Given this list of marker genes Vmn1r217, Gm11371, Gm8245, Gm11307, Prl4a1, 4930557F10Rik, Gm11320, Snrp1c-ps2, Bphl, Ripor2, Serpinb9g, Gm5194, Gm47978, H4c9, Prss16, Gm40841, 4930511O05Rik, Vmn1r196, Gm30489, Vmn1r201, Gm22126, Gm11321, Serpinb1b, Zscan26, Rps17-ps1, Gm25186, Vmn1r190-ps, 4932702P03Rik, Fam217a, Gm11270, Cage1, Gm22452, H3c10, Bmp6, Gm11354, Prpf4b, Gm11394, Gm47754, Vmn1r-ps109, Vmn1r199, Serpinb9h, Prl3a1, Eci3, Gm46411, Gm36099, Prl8a1, Vmn1r-ps126, Gmnn, Vmn1r-ps133, E2f3, Gcm2, Vmn1r-ps101, Vmn1r-ps106, Vmn1r218, H2ac15, Or2b6, H2ac7, Prl7a2, H4c18, Tmem14c, Aldh5a1, Gm23774, Slc17a3, Gm8352, Vmn1r222, Gmds, Gm11355, Gm11366, H3c11, Prl3b1, Dcdc2a, Vmn1r194 (NCBI Gene Id 632575), D130043K22Rik, H2bc7, Vmn1r-ps125, Gm11381, H2bc23, BC005537, H2ac6, Nrn1, Gm35732, Lncbate6, Prl8a8, 2210022D18Rik, Mir1983, H2ac14-ps, Gm23351, Sycp2l, Gm29590, Gm40918, Prl3d2, Vmn1r-ps132, Hdgfl1, Gm8277, Nrsn1, H4c1, Vmn1r207, Serpinb9e, Gpx5, H1f3, Gm11360, Gm11298, H2bc12 (NCBI Gene Id 319184), Gm23206, H3c1, Ssr1, Gm40923, Gm11359, Gm5195, H2ac22, Rreb1, Vmn1r219, H2bc14, Dsp, Serpinb1-ps1, H4c2, 1110046J04Rik, Gm11282, Vmn1r221, 4933404K08Rik, Vmn1r-ps99, Prl2b1, Vmn1r188, Vmn1r210, Scgn, Tubb2b, Ripk1, Vmn1r205, H2bc6, Smim13, H2bc11, H1f5, Prl8a6 (prolactin family 8, subfamily a, member 6), 4930579J19Rik (RIKEN cDNA 4930579J19 gene), 5530402G07Rik, Btn2a2, Prl7b1, Gm40909 (predicted gene, 40909), Cmah, Gcnt2 (NCBI Gene Id 78281), Vmn1r223 (NCBI Gene Id 626774), Slc17a1, Agtr1a, H1f2, Gm10129, Gm19153, Zkscan8, A730081D07Rik, A230103O09Rik, Btn1a1, Acot13, Pxdc1, H4c3, Prl3d1, Gm3509, 5033403F01Rik, H1f1, Vmn1r202, H1f4, Gm22013, H2bc13, Prl2a1, Or2b7, Nqo2, Gm36500, Riok1, Prl8a9, Or2w6, Prl7a1, Gm35160, Prl3c1, Gm47038, Sox4, Gm11279, Vmn1r-ps113, Prl7c1, Gm40922, Serpinb9, Tfap2a, 1700018A04Rik, Vmn2r-ps94, Gm11285, Gm11353, Gm18881, Psmg4, Gm36758, Gm26688, H2ac1, Vmn1r-ps103, Tex56, 4930519D14Rik, Gm11378, Vmn1r204, H4c6, Foxq1, Gm23972, H4c11, Gm11372, H1f6, Mir5124a, Mir6368, Gm11350, Foxf2, Gm11278, Abt1, Gm23340, Or2w2, Vmn1r203, H2ac12, Vmn1r195, Zfp184, Gm5447, Prl3d3, Vmn1r-ps131, Gm11363, Vmn1r-ps112, Vmn1r-ps123, 1700019C18Rik, H2ac5-ps, Gm31834, H3c6, Lyrm4, H4c17 (H4 clustered histone 17), Gm11271, Prl, Gm11349, Vmn1r-ps94, Mboat1, Gm26395, Gm11362, Hfe, Tubb2a, 4930401O12Rik, Vmn1r-ps117, Mak, Serpinb1c, Serpinb9b, Gm31683, Gm11281, Gm11341, Gm11380, Vmn1r-ps120, Gm11342, A330102I10Rik, 9330162012Rik, Zkscan3, H3c3, Gm11322, Gm11377, 4930586N03Rik, H3c4, H2bc15, Wrnip1, Vmn1r211, Zkscan4, Gm22330, Gpx6, Gm11370, Serpinb9c, H2bc22, Vmn1r209, Vmn1r-ps108 (vomeronasal 1 receptor, pseudogene 108), H2bc4, Mrs2, H2ac24, Gm11338, H2ac23, 2610307P16Rik, AK157302, H2bc9, Mir1896, Foxc1, Gm11387, Serpinb6a, Vmn1r-ps111, Zfp389, Gm11398, Vmn1r193, H2ac13, 4930447K03Rik, H2ac4, Gm6129, A730091E23Rik, G630018N14Rik, Cdkal1, Serpinb6c, Ppp1r3g, Slc22a23, Prl8a2, Gm16984, H2ac11, Vmn1r-ps97, Vmn1r-ps107, Vmn1r-ps127 (vomeronasal 1 receptor, pseudogene 127), Gm9979, Gm4035, Vmn1r-ps102, Fam50b (family with sequence similarity 50, member B), Gm11292, Or2b2b, Vmn1r216 (vomeronasal 1 receptor 216), Gm36839, Vmn1r191, H4c4, H2bc3, Snrnp48, H4c12, Or2w4, Zscan12, Vmn1r200, Vmn1r214, Vmn1r197, C230035I16Rik (NCBI Gene Id 320842), Gm11295, Slc17a4, Gm6245, Slc35b3, Vmn1r-ps96, Gm46409, Or1f12, Pgbd1, H3c2, Gm22674, Slc17a2, Dusp22, 4933436N17Rik, Gm11351, 4930470G03Rik, Ly86, Irf4, Gm11379, H3c8, Gm18643, Vmn1r-ps92, Vmn1r208, Gm46392, Serpinb6b, H2bc8, Gm23779, Gm47990, H4c8, Vmn1r192, Prl2c1, Vmn1r-ps128, Gm11274, Uqcrfs1, Gm40828, Gpld1, AI463229 (expressed sequence AI463229), Gm11337, Tdp2, Serpinb1a, Gm11343, H2ac10, Txndc5, Gm11392 (NCBI Gene Id 624716), Bloc1s5, Gm11318, Cox5b-ps, Vmn1r212, Pak1ip1, Mylk4, Vmn1r220, Gm22358, Rpp40, 1700092E19Rik, Vmn1r-ps100, Vmn1r-ps114, Eef1e1, H2ac8, Gm11357, Vmn1r215, Pom121l2, Rps18-ps5, Serpinb9d, H2bc1, Gm11383, Gm32243, Vmn1r213, Gm8231, Gm46404, Gm31600, Tpi-rs8, Hus1b, Elovl2, Trim38, Gm11352, Serpinb6d, Cdyl, H3c7, Carmil1, Vmn1r189, Nkapl, Gm11346, Vmn1r-ps135, Gm11335 (predicted gene 11335), Eci2, Tmed10-ps, Gm15908, Gm18132, Serpinb9f, Prl7d1, Gm6081, Vmn1r-ps104, Gm30177, Gm6200, Gm7201, Or2b28, Gm11386, Armh2, Gm34165, Serpinb6e, 1700011B04Rik, H2bc24, Vmn1r198, Gm11334, Mir6942, Vmn1r-ps93, Gm30127, Vmn1r-ps95, Or2b2, Prl6a1, 4930558J22Rik (NCBI Gene Id 218102), F830002E08Rik, Exoc2, Gm34639, Gm30600, Gm32063, Vmn1r-ps116, Zfp322a, F13a1, Gm11284, Ofcc1, Prl5a1, Vmn1r-ps110, Gm6093, Fars2, Vmn1r206, here is a description of the gene set: species: Mus musculus Mouse Gene Set: chr13A3